The following is a description of a gene set: part of: Cholesterol biosynthesis Reactome Pathway: Zymostenol biosynthesis via lathosterol (Kandutsch-Russell pathway) studied in species Homo sapiens The transformation of zymosterol into cholesterol can follow either of routes, one in which reduction of the double bond in the isooctyl side chain is the final step (cholesterol synthesis via desmosterol, also known as the Bloch pathway) and one in which this reduction is the first step (cholesterol biosynthesis via lathosterol, also known as the Kandutsch-Russell pathway). The former pathway is prominent in the liver and many other tissues while the latter is prominent in skin, where it may serve as the source of the 7-dehydrocholesterol that is the starting point for the synthesis of D vitamins (Kandutsch & Russell 1960; Mitsche et al. 2015)., and this is the list of marker genes: TM7SF2, DHCR24, CYP51A1, SREBF2, SREBF1, MSMO1, HSD17B7, NSDHL